The following is a description of a gene set: Mouse Gene Set: GOBP_CELL_MIGRATION_INVOLVED_IN_GASTRULATION The migration of individual cells within the blastocyst to help establish the multi-layered body plan of the organism (gastrulation). For example, the migration of cells from the surface to the interior of the embryo (ingression). species: Mus musculus, and this is the list of marker genes: Lrp5, Gpc3, Epb41l5, Mixl1, Fgf8, Nodal, Lefty1, Cer1, Nckap1, Megf8, Sox17, Amot, T (brachyury, T-box transcription factor T), Ric8a, Apela, Crb2, Lrp6